The following is a description of a gene set: Human Gene Set: GOBP_HIPPOCAMPUS_DEVELOPMENT species: Homo sapiens The progression of the hippocampus over time from its initial formation until its mature state., and this is the list of marker genes: PIANP, NR2E1, HDAC1, OGDH, XRCC1, CFL1, CDK5R2, RELN, PHLPP2 (PH domain and leucine rich repeat protein phosphatase 2), POMT2, ZEB2, XRN2, ATG16L1, LMX1A, FXR2, NR4A3, HTR5A, SCT, DLX2, SRD5A1, DRD1, PAFAH1B1, RAN, NEUROD6, WNT3A, FXR1, KIF14, ZIC1, ALK, BTG2, SLC32A1, CDK5R1, PROX1, KCNA1, EIF2B5, POMGNT1, NKX2-1, DLX1 (distal-less homeobox 1), MDK, SMO, GLI3, PLXNA3, NEFL, ATAT1, YWHAE, LARGE1, LRP8, PTEN, FBXO41, BLOC1S6, CRK, CASP3, ID4, KDM6B, EMX2, FEZ1, VPS13B, SRF, CRKL, GSK3B, FGF13, TSKU, UQCRQ, TSC1, CDK6, DAB1, MKKS, LEF1, SRD5A2, RARA, DCLK2, PPP1R9B, NEUROD1, BCAN, SEMA6B, LHX5, EPHA5, BBS1, NCOA1, KIRREL3, PTPRS, ZIC3, EZH1, BBS2, EZH2, TMEM108, NF2, MFSD2A, CDK5, TUBA1A, ATP2B4, BBS4, FEZF2, TP73